Given this list of marker genes TAOK1, HHEX, FLNC, ADAP1, MLLT6, ERG, CCDC88B (NCBI Gene Id 84211), BDNF, RNF138, MEF2C, RBFOX1, ARV1, HGFAC, HTR3B, TMC3, PDE4D, GRIN2B, RGS3, ZNF485, HOXA2, ATP13A2, PKN3, GNB2, LAG3, ITGA8, LNX2, GPN2, MPO, CRK, TSPOAP1, NOSTRIN, GLT8D2, TRPS1, VPS39 (NCBI Gene Id 23339), ACAP2, FOXO3, DHH, TRERF1 (NCBI Gene Id 9565), KDM5C, STAT5A, SAP130, CLNK, DNAJA2, DOCK11, GNGT2, SPDEF, USP2, SGK1, HMGA1, LRP2, DNAJC7, TMUB2, SPI1, NMNAT2 (NCBI Gene Id 23057), EGF, JADE2, MTUS1, EMC3, ZNRF2, TSEN54, MRPL24, VASP, SNX8, TOM1L1, SATB1, PLEKHH2, CHD6, MARCKSL1, PDLIM2 (NCBI Gene Id 64236), MAP4K2, PIM2, HOXB4, PPP2R5C, VAMP3, ZDHHC8, CALCOCO1, CAMK1D, DLC1, GNL2, PRR5L, PHF12, VAV3, GREM1, PIH1D2 (PIH1 domain containing 2), MBNL1, FGF13, EDN1, OCIAD2, SCN2A, AKR7L, TNFSF13, PEG10, BMP2, TCF15, FLI1, PRPF38B, ADCYAP1, CEP83, LRRC32, MAP3K3, GPHN, CA3, ADSL, FAM20A, PAX8, CRYGB, ERF, FAM110A, IL7R, SLC35C1, RHOJ, LRRC19, SEMA4B, HYPK, CSF3R, RNF128, PGM2L1, CYTH4, RAB3GAP2, TBC1D17, DCTN2, AKT1S1, EGFL7, LAT, ZNF706, PPP4R3B, HOXA10, ASPN, SYTL1 (synaptotagmin like 1), STK4, FAM78A, ANKRD28, FBXW11, ALPK2, TMEM59L, WNT5A, FEV, PUM1 (pumilio RNA binding family member 1), SLC38A2, FEM1C, RANBP9, LINC00314, ASTN1, PLEKHA8P1, CSF2, CNN2, PDGFRB, TRIM25, GSC, ANGPTL1, CARD9, SPEM1, EIF1, ZRANB1, SDCBP, SASH3, LTC4S, POU3F3, NFAT5 (nuclear factor of activated T cells 5), ZBTB37, PITPNC1, KNL1, CYB561D2, STRC, STAB1, TLL1, CRTC2, SCGB3A1, SLC43A1, STX19, POLR1D, ARFGAP2, PATL1, CITED2, LRIT3, STAP1, EPHA2, PAX9, KY, SESTD1, RHBDL3, HOXB9 (NCBI Gene Id 3219), TFEC (transcription factor EC), TTC13, NOTCH4, GPX1, TWIST1, CBLB, LALBA, ZNF202, ATP5F1E, SKAP2, LINC03122, CD274, RUNX3, HIF3A, TRAF3, KANSL1, CTNNB1, ACBD6, PLCB2, CTTNBP2NL, GZMK, ZNF385B, SLC31A1, RBBP5, SRRM1, CDKL5, GPS2, CLOCK, CASKIN2, RAB39A, FLT1, CTCF, CPA3, EPHA7, RAB1B, HIVEP1, CITED4, SIPA1 (signal-induced proliferation-associated 1), ZEB2, CACNG3, ABI3 (ABI family member 3), PREX1, LY75, PSTPIP2, TMPRSS11D, TANK, CD200R1, HNRNPUL1, HSD11B1 (hydroxysteroid 11-beta dehydrogenase 1), ARAP3, ARID1A, PDCD10, DIPK2B, NKAPD1, TMIGD1, NPRL2, CPEB4, LCK, CD2AP, DOK3, ITPR3, SERPINI1, CMYA5, TSC22D4, PRKCB, SLIT3, MCTS1, KCNQ1, PDZRN4, RIN2, MEIS2, NKIRAS2, COX17, LUC7L, MRGPRG-AS1, DOCK4, SLC1A5, CREBZF, here is a description of the gene set: Genes having at least one occurrence of the motif NNYTTCCY in the regions spanning 4 kb centered on their transcription starting sites. This matches the STAT6 transcription factor binding site V$STAT6_02 (v7.4 TRANSFAC). Human Gene Set: STAT6_02 species: Homo sapiens